Given this list of marker genes ATRN, ASB11 (ankyrin repeat and SOCS box containing 11), SP1, TMEM260, RPS6KA5, MICAL2, TSHZ3, LMO7, FANCF (FA complementation group F), CAST, LRIG1, MEX3C, ANKRD12 (NCBI Gene Id 55606), KDM6A, HMGXB4, PLCB4, EIF4ENIF1, RAB5B, ZSWIM2, NDST3, PHIP, ADM, NFAT5, IKBIP (IKBKB interacting protein), SLC12A1, KANSL1L, CACNA1B, KCNH7, PRSS12, MAML3, CD1E, FAM120C, MBL2, TMEM33, EYS, GADL1, RUNX2, EPHA7, CYRIA, ALG10B, FST, LRRC31, SLITRK1, SLC8A1, EXO5, FZD5, TRMT61B, CPEB2, TBC1D32, SAMD13, HGF, P2RY13, CD59, C3orf38, MBIP, TIMM17A, ZDHHC21, TBK1, SEC24B, ACTBL2, CHMP4C, REEP4, SLU7, HYAL4, SLC24A2, BTBD3, MSI2, RPGRIP1L, MERTK, RIOX2, PIK3R1, ZIC3, SENP1, CSMD1, DENR, SPOPL, CD36, RAPGEF4, RBPJ, MBNL3, LPP, MALT1, AMMECR1, ZNF479, NAMPT, GEMIN2, BMP2, PLD5, NCAM2, HDGFL3, HSPE1-MOB4, ZFYVE1, AFG2A, GSK3B, SPDYE1, DNAJC25-GNG10, TCF7L2 (NCBI Gene Id 6934), SSH2, NUFIP2, VPS13C, HNRNPU, ITGBL1, CEP44, ZNF138, ZBTB18 (zinc finger and BTB domain containing 18), CELF2, ETS1, KRTAP4-3, FGF9, FLT3, OTULINL, TSPAN2 (tetraspanin 2), PPP4R2, ZNF484, DNAJC25, RAI1, YIPF4, BDNF, PCDH10, PARVA, CDH2, LUM, GNG10, PCGF2 (NCBI Gene Id 7703), MGAT4A, BTBD1, LMO3, HIVEP1, SPIRE2, BICDL1, BTG1, SCN3A, ALCAM, NXPH1, TMEM178B, TET1, TRAPPC8, SP4, VAMP2, DUSP8, VSTM4, CCDC85A, APOOL, PELI1, LARP6, CSNK1G3, MYO5B, PI15 (peptidase inhibitor 15), IL1RAP, RBM23, HOOK3, GABRB3, SLITRK4, PRRG4, ZBTB41, RABGGTB, SCYL1, PTER, SLC2A11, ZNF716 (zinc finger protein 716), CARTPT, PPIL4, PTGER3, PLEKHF2, CDKN1B, COMMD2, KCNH5, ABCA6, ODF1 (outer dense fiber of sperm tails 1), GTF3C3, LRRC59, SLK, CREBBP, ZNF117, DTL, MTREX (NCBI Gene Id 23517), FNDC3A, RC3H1, NR4A2, GABRG3, ZNF268 (zinc finger protein 268, NCBI Gene Id 10795), NRBF2, FRMD4B, SPDYE6, USP53, RTKN2, AJAP1, SLC38A2, BCOR (BCL6 corepressor), MEF2A (myocyte enhancer factor 2A), MIER3, TXLNB (taxilin beta), SSBP2, CDK14, SLC38A3, CFAP69, CLASP2, INTS8, CLEC7A (C-type lectin domain containing 7A), FRMPD4, LRATD1, MYF5, GRIA2, LPCAT2, NME5, KIAA1958 (KIAA1958), JMJD1C, MRS2, WDR91, LOX, SMTNL2, GUCY1A2, ZBTB10, ZNF829, MFSD14A, DACH2, RIC8B, ANKRD17, SCN2A, CLINT1, LYPLA1, DGKH, ZNF606, ARHGAP5, MAN1A1, ENPP6, CNTNAP4, FBLN7, CGNL1, PRELID3A, ADAMTS9, ATP8A1, ZCCHC8, ARHGEF6, TSEN15, FBXL14, ARHGEF38, CD9, ZNF608 (zinc finger protein 608), SUMO2, DOCK9, RORA, KIAA1586, BCDIN3D, TLR4, ATF1 (NCBI Gene Id 466), PDZRN3, SLAMF1, PLXDC2, TANC1, ABI1, NDNF, C1orf21, PDE10A, DYRK4, ZNF529, ADAM9, SRGAP3, SUV39H2, PCDHB7, PDXDC1, WDR20, TMEM41B, SLC25A21, CREBZF, WWC3, PSD2, TMEM108, PRKCD, IQCE, FAM135B, YPEL4, BRD10, CAVIN2, PABIR1, TENT4B, SIKE1, BVES, DCLK1, GASK1B (golgi associated kinase 1B), FBXO45, GBX2, GTF2B, KALRN, SLC20A2, ANKRD28, GPSM2, TGFBR2, RFX3, UBE2B, ITGA2, CIMIP2B (ciliary microtubule inner protein 2B), CERKL, LRRC28, PEX3, YME1L1, MOB4, ATP1B4, TRIM33, GOLGA5, PHF20L1, MED23, C1orf52, TMC8, CRPPA, HOMER1, MCEE, ADH6, MAP3K12, ZNF699, PPP3R1, STIP1, TTF1, RMND5A, CACNA1G, CMPK2, KCNJ3, KDM4B, SPDYE3, IRAK1BP1, RNF138, ATP6V1G1, NFIX, TJP1, FAM169A, SUPT20H, PRDM1, ADGRD1, AEBP2 (AE binding protein 2), SLC18B1, ASAP2, KLHL23, KIAA0586, IMPA1 (NCBI Gene Id 3612), NEUROD1, KHDRBS1, HMGB2, TRAK1, SPDYE5 (NCBI Gene Id 442590), MMP12, here is a description of the gene set: studied in species Homo sapiens Human Gene Set: MIR3924 from publication Chen Y, Wang X (PMID 31504780) Genes predicted to be targets of miRBase v22 microRNA hsa-miR-3924 in miRDB v6.0 with MirTarget v4 prediction scores > 80 (high confidence targets).